The following is a description of a gene set: A cytotoxic enterotoxin (Act) of Aeromonas hydrophila possesses several biological activities, and it induces an inflammatory response in the host. In this study, we used microarrays to gain a global and molecular view of the cellular transcriptional responses to Act and to identify important genes up-regulated by this toxin. Total RNA was isolated at 0, 2, and 12 h from Act-treated macrophages and applied to Affymetrix MGU74 arrays, and the data were processed using a multi-analysis approach to identify genes that might be critical in the inflammatory process evoked by Act. Seventy-six genes were significantly and consistently up-regulated. Many of these genes were immune-related, and several were transcription factors, adhesion molecules, and cytokines. Additionally, we identified several apoptosis-associated genes that were significantly up-regulated in Act-treated macrophages. Act-induced apoptosis of macrophages was confirmed by annexin V staining and DNA laddering. Quantitative reverse transcriptase-polymerase chain reaction (RT-PCR) and enzyme-linked immunosorbent assay were used to verify increased expression of some inflammatory and apoptosis-associated genes identified by the microarray analysis. To further confirm Act-induced increases in gene expression, real-time RT-PCR was also used for selected genes. Taken together, the array data provided for the first time a global view of Act-mediated signal transduction and clearly demonstrated an inflammatory response and apoptosis mediated by this toxin in host cells at the molecular level. species: Mus musculus from publication Galindo CL, Sha J, Ribardo DA, Fadl AA, Pillai L, Chopra AK (PMID 12824169) Human Gene Set: GALINDO_IMMUNE_RESPONSE_TO_ENTEROTOXIN Genes up-regulated in macrophages by aerolysin-related cytotoxic enterotoxin (Act) from Aeromonas hydrophila., and this is the list of marker genes: ADORA2B, BCL10, BHLHE40, IL1RN, ERRFI1, NOCT, ODC1, SCD, NFKB1, RAC2, EHD1, CDC42EP4, MARCKSL1, TSC22D1, CSF3, PDGFA, ITGA5, NAB2, ACOD1, SLFN12, SPP1, CD83, NFKB2, CD44, ETS2, RREB1, PIM1, PCDH7, CEBPB, PTGS2, IL1B, UBC, GADD45A, TRAF1, MT1X, TNFAIP3, CCL3, CXCL2 (NCBI Gene Id 2920), SOCS3, CSF2RB (NCBI Gene Id 3564), NFKBIA, PHLDB1, GLRX, JUNB, SQSTM1, TNIP1, BCL2L11 (NCBI Gene Id 150819), SLC11A1, CCL4, TXNIP, GADD45B, TNF, FOSL1, DUSP2, TAPBP, TNFSF9, PKM, HERPUD1, IL18RAP, CD14, BCL6B, GAPDH, BCL3, CCL15, PLAUR, PTPRE (protein tyrosine phosphatase receptor type E), CCL5, ACTG1, UBB, TNFAIP2, PDLIM7, VEGFA, DUSP1, PHLDA1, IKBKE, IER3, SRPRA, RHOB